The following is a description of a gene set: Human Gene Set: GSE17721_LPS_VS_POLYIC_2H_BMDC_DN mouse primary BMDCs were stimulated with tlr ligands and gene expression changes were profiled on Affymetrix arrays species: Homo sapiens from publication Amit I, Garber M, Chevrier N, Leite AP, Donner Y, Eisenhaure T, Guttman M, Grenier JK, Li W, Zuk O, Schubert LA, Birditt B, Shay T, Goren A, Zhang X, Smith Z, Deering R, McDonald RC, Cabili M, Bernstein BE, Rinn JL, Meissner A, Root DE, Hacohen N, Regev A (PMID 19729616) Genes down-regulated in comparison of dendritic cells (DC) stimulated with LPS (TLR4 agonist) at 2 h versus DC cells stimulated with poly(I:C) (TLR3 agonist) at 2 h., and this is the list of marker genes: TGDS (TDP-glucose 4,6-dehydratase), RPL9, BIN3, ZNF322, MED20, E4F1 (NCBI Gene Id 1877), PYROXD1, NUDT2, SKP2, METTL25B, GNE (glucosamine (UDP-N-acetyl)-2-epimerase/N-acetylmannosamine kinase), EEPD1, FANCF, FAF1 (Fas associated factor 1), ZFP90, CYFIP2, COA5, ADAMTS15, AXIN1, CCR5, CDC6, WDR1, TMUB2, UBE2D1, C1D, GOT2, TMEM134, ANGEL2, SESN1, EEF1B2, ARHGEF25, GTF3C4, ZNF148, NEUROG2 (NCBI Gene Id 63973), CBFA2T2, GIT1, MED4, SOX4, SYPL1, MAFB, ZFYVE19, NUP37, SEC11A, EIF2S3 (eukaryotic translation initiation factor 2 subunit gamma), CD200R1, MRPS14 (mitochondrial ribosomal protein S14), FUBP1, MTMR10, DHX57, FAM118B, SPINT1, RGL2, CD244, TRIM8, ATOSB, SARAF, USP20, DENND4C, SLC35F6, OAS2, NCKAP1L (NCBI Gene Id 3071), CPPED1, POT1, AP1AR, RASSF7, PREB, FGGY, PSMD5, PLD1, PDCD6, C8orf33, RPS26, IREB2, ELMO2, CLTA (clathrin light chain A), KLF4, TNPO1, TBX5 (NCBI Gene Id 6910), ERP29, SLC25A28, TOPBP1, CDK14 (cyclin dependent kinase 14), NAT1, NIT1, LIPT2, ETFRF1, RIOK3, POLR3E, CAPRIN2, SAMHD1, GLRX2, CRTAP, ZFAND2A, IER3IP1, PTGER2, KIF1C, PAXBP1, PLP2, RAP1GDS1, CLN8, KLHL42, DNAJC5, KDM5B, NUDT3, RNF187, NUFIP1, COMMD7, PNPT1, TOP3A, POLD2, GSTZ1, ABL1, RAN, C19orf53, HTATSF1, SH3BP2, SNRNP48, HVCN1, MLYCD, MCM2, ESYT1, KHDC4, NEK9, THYN1 (thymocyte nuclear protein 1), RPAP2, ASCC2, SP3 (Sp3 transcription factor), TMEM140, SPEN (spen family transcriptional repressor), TOR3A, AKAP8, ATP13A2, FEZ2, SYNE4, C1orf174, CDKN2AIPNL, MGAT2, TMEM51, MANBAL, ARL14EP, UBR3, CDC26, CYB5A, TBXAS1, EHBP1L1, HES6, OMA1, SRP19, STK38, TTI1, EMG1 (NCBI Gene Id 619532), ORC6, SIGMAR1, HMGXB4 (NCBI Gene Id 96789), KRT15, GRIA2, OVOL2, LDB1, LUC7L2, MICAL1, PISD, ZBTB7B, DNAJC30, COPS3, ACTR1A, PSMD2, SNX6, ILK, DNMT3A, TEFM, KLF13, NOP2, XRN1, PPP1R14B, ALKBH4, CCDC6, POLR2D, SDHAF1, PHKB, CXCR4, RANBP3, GTPBP2, FAM117A, CMTM6, NAA30 (N-alpha-acetyltransferase 30, NatC catalytic subunit), B3GALT6, FAM118A, MRPL44, FAM8A1, ARMC10, AEN, HAUS3, XPR1, KRT80 (keratin 80), ASH1L, MORC3, SNX2, PDE8A, PACS2, YAE1